The following is a description of a gene set: Reactome Pathway: FGFR1c and Klotho ligand binding and activation part of: FGFR1 ligand binding and activation FGF23 is a member of the endocrine subfamily of FGFs. It is produced in bone tissue and regulates kidney functions. Klotho is essential for endogenous FGF23 function as it converts FGFR1c into a specific FGF23 receptor. species: Homo sapiens, and this is the list of marker genes: KL, FGF23, FGFR1